Given this list of marker genes Thy1, Plg, Rtn1, Ophn1, Shh, Dpysl2, Cdk5r1, Celsr1, Slit1, L1cam, Tle1, Nf1, Myh9, Gli1, Pml, Ptch1, Scg2, Crmp1, Nrp2 (NCBI Gene Id 68752), Vldlr, Cdk6, Amot (NCBI Gene Id 97610), Vegfa, Cntfr, Rasa1, Hey1, Nrcam, Ache, Adgrg1, Nkx6-1 (NCBI Gene Id 18096), Tle3, Nrp1, Hey2, Unc5c, Ldb1 (NCBI Gene Id 16825), Ets2, here is a description of the gene set: Mouse genes annotated to HALLMARK_HEDGEHOG_SIGNALING based on orthology mappings provided by the Alliance Genome Consortium from publication Howe DG, Blake JA, Bradford YM, Bult CJ, Calvi BR, Engel SR, Kadin JA, Kaufman TC, Kishore R, Laulederkind SJF, Lewis SE, Moxon SAT, Richardson JE, Smith C (PMID 30224793) studied in species Mus musculus Mouse Gene Set: HALLMARK_HEDGEHOG_SIGNALING